Given this list of marker genes Fen1, Pold4, Pold2, Dna2, Pola1, Pcna, Prim1, Rpa3, Pold3, Rpa2, Lig1, Rpa1, Pold1, Prim2, Pola2, here is a description of the gene set: Processive synthesis on the lagging strand species: Mus musculus Mouse Gene Set: REACTOME_PROCESSIVE_SYNTHESIS_ON_THE_LAGGING_STRAND